Given this list of marker genes CDK7, POLR2F, SUPT5H, CCNH, RNGTT, POLR2J, ERCC3 (NCBI Gene Id 2071), POLR2H, POLR2B, GTF2F1, POLR2D, MNAT1, POLR2E, GTF2F2, POLR2A (RNA polymerase II subunit A), POLR2G, POLR2L, GTF2H5, GTF2H4 (general transcription factor IIH subunit 4), RNMT, POLR2C, GTF2H3, ERCC2, GTF2H2, POLR2K, POLR2I, GTF2H1, here is a description of the gene set: studied in species Homo sapiens To facilitate co-transcriptional capping, and thereby restrict the cap structure to RNAs made by RNA polymerase II, the capping enzymes bind directly to the RNA polymerase II. The C-terminal domain of the largest Pol II subunit contains several phosphorylation sites on its heptapeptide repeats. The capping enzyme guanylyltransferase and the methyltransferase bind specifically to CTD phosphorylated at Serine 5 within the CTD. Kinase subunit of TFIIH, Cdk7, catalyzes this phosphorylation event that occurs near the promoter. In addition, it has been shown that binding of capping enzyme to the Serine-5 phosphorylated CTD stimulates guanylyltransferase activity in vitro. part of: Transcription of the HIV genome Reactome Pathway: RNA Pol II CTD phosphorylation and interaction with CE during HIV infection